The following is a description of a gene set: Mouse Gene Set: GOBP_REGULATION_OF_TRANSLATION_IN_RESPONSE_TO_STRESS Modulation of the frequency, rate or extent of translation as a result of a stimulus indicating the organism is under stress. The stress is usually, but not necessarily, exogenous (e.g. temperature, humidity, ionizing radiation). species: Mus musculus, and this is the list of marker genes: Ddx3x, Eif4g1, Hbb-bs, Fech, Map3k20, Tmed2, Sesn2, Eif2ak4, Krt13, D1Pas1, Eif2s1, Eif2ak3, Impact, Nck1, Slc35a4, Npm1, Eif2ak1, Nck2, Ang, Ppp1r15a, Prkch, Rbm4, Pml, Dnajc3